Given this list of marker genes Pde7a, Fgf11, Ubn2, Krt6b, Aak1, U2surp, Tmem106b, Cand1, Ccdc103 (coiled-coil domain containing 103), Mesd, Gp1bb, Pafah1b1, Arl15, Ms4a1, Eif2ak3, Gpd2, Fktn, Unc13c, Bcl7a, Txlnb, Prkca, Hoxb9, Nxph2, Atp1b2, Rgs8, Nup37, Zfp626, Cmpk1, Nptx1, Suz12, Gabra4, Arnt2, Kpna1, Terb2, Slc10a2, Tlcd4, Ctsl, Vldlr, Ptprn, Ubap2l, Fgf12, Armcx3, Rimbp2, Hnrnpr, Gcnt7, Prmt3, Msrb3, Negr1, Zbtb43, Npr3, Tspan13, Krtap24-1, Armc8, Lin7a, Rmdn2, Prr15, Mat2a, Gins3, Kl, Atf3, Acer3, Bmpr2, Kras, Crebrf, Rora, Mmut, Map2, Znrf3, Tet1, Myo1a, Il20ra, Arhgap28, Spag9, Gdf10, Cdca7l, Uchl5, Tlk1, Septin7, Smu1, Fbxo11, Lcorl, Wdr26, Arl4a, Dusp1, Creb1, Coq7, Smg8, Slc12a6, Smad2, Ccnl1, Trim33, Id4, Scn3a, Smarcal1, Cggbp1, Eif5a2, Fndc3a, Slc8a1, Plin3, Tef, Ncbp3, Dennd4c, Dennd10, Ano5, Zic3 (zinc finger protein of the cerebellum 3), Pawr, Il5ra, Ficd, Elp1 (elongator complex protein 1), Sh3kbp1, Cep19, Tex11, Tlr4, Agr2, Mthfd2, Lpp, Nhsl2, Marf1, Casp14, Dcaf10, Cltrn, Ccdc169, Ica1l, Nipal2, Wars2, Tenm4 (NCBI Gene Id 97426), Adgrg6, Btla, Fbxo16, Gcnt3, Mthfd1l, Aff1, Mindy2, Ddr2, Daam1, Kcnj14, Gbp3, Zfp518b, Lrrc2, Sema6d, Cyp2c50, Pdik1l, Anks1b, Sh3bgrl2, Hebp1, Rdh10, Trpm3, Hao1, Scel, Snx4 (sorting nexin 4), here is a description of the gene set: studied in species Mus musculus from publication Chen Y, Wang X (PMID 31504780) Genes predicted to be targets of miRBase v22 microRNA mmu_miR_7225_3p in miRDB v6.0 with MirTarget v4 prediction scores > 80 (high confidence targets). Mouse Gene Set: MIR_7225_3P